The following is a description of a gene set: studied in species Homo sapiens CD25, the high affinity interleukin-2 (IL-2) receptor alpha-chain, is rapidly upregulated by antigen-specific CD8+ T cells after T cell receptor stimulation. We demonstrated that during an acute viral infection, CD25 expression was dynamic, and a subset of virus-specific CD8+ T cells sustained CD25 expression longer than the rest. Examination of the in vivo fate of effector CD8+ T cells exhibiting differential responsiveness to IL-2 revealed that CD25lo cells, which were relatively less sensitive to IL-2, preferentially upregulated CD127 and CD62L and gave rise to the functional long-lived memory pool. In contrast, CD25hi cells that accumulate enhanced IL-2 signals, proliferated more rapidly, were prone to apoptosis, exhibited a more pronounced effector phenotype, and appeared to be terminally differentiated. Sustained IL-2 receptor signaling resulted in increased CD8+ T cell proliferation, higher granzyme B expression and exaggerated contraction after antigen clearance. These data support the hypothesis that prolonged IL-2 signals during priming promote terminal effector differentiation of CD8+ T cells. Genes up-regulated in comparison of naive vs effector CD8 T cells (3.5 days postinfection). from publication Kalia V, Sarkar S, Subramaniam S, Haining WN, Smith KA, Ahmed R (PMID 20096608) Human Gene Set: GSE19825_NAIVE_VS_DAY3_EFF_CD8_TCELL_UP, and this is the list of marker genes: ATP1B1, SNED1, TTC3, CRISPLD1, APLP2, HHIP, LIX1, ZFX, SLC22A25, IGF2BP1, SV2A, CYP11A1, PTCH2, PARD3, IGFBP4, ASTL, EPDR1, SPARCL1, GPR182, SYN1, MOBP, DIO3OS, UROC1, KCNA2 (NCBI Gene Id 3737), ANO1, ADAMTS9, ART1, SPTBN2, PAPSS2 (3'-phosphoadenosine 5'-phosphosulfate synthase 2), TTLL10, ACVR1, STMN4, FUT9, ZNF420, NEUROG3, LEPR, GAS1, MYH6, ANGPT4, YIPF7, CORO2B, NREP, PAX3, SLC2A5, FOXA2, CRACD (capping protein inhibiting regulator of actin dynamics), IGSF21 (immunoglobin superfamily member 21), KCNK13, POMT2, CLRN3, PLCL1, HCN3, TUBB4A, ARHGEF40, C16orf86, PTGS2, PCLO (piccolo presynaptic cytomatrix protein), EPN2, NRIP2, BACE2, TNFRSF11A, FAM90A13 (NCBI Gene Id 619424), LCE2B, ST6GALNAC1, XPNPEP2, HSD3B1, CCDC22, GPR12, FAM227A, VGLL3, ADGRE1, REM2, CIMIP6, TFAP2A, ELAVL4, MTUS2, COL5A2, MACROH2A2, IGF1R, TMEM266, SLC12A8, TMEM86B, PIGP, PRR16 (NCBI Gene Id 51334, proline rich 16), ZFPM2, INTU, TFF3, DRP2, ZNF691, FCGR2B, LBP, DYDC2, CSF3, CFI, BPIFA2, ZNF536 (NCBI Gene Id 9745), COPZ2, WNT1, SH3GL3, TMEM8B, FRS3, SRPK3, ADARB1, TSPAN7, CRYL1, HDAC11, VSTM2L, TEX13A, KRT75, SLC35F1, GDF3, SPATA3, SEMA3F, CYFIP1, GOT1L1, LOXL2, FAM78B, ADD2, AIF1L, TRPA1, PCDHB12, PLA2G6, GPR26, PNMA3, COL8A1, CTSK, SLC29A4, KCND2, NXPH1, DNAH6, DACT3, HTRA3, BDKRB1, SCML2, RHBDL3, DPYSL4, EPCAM (epithelial cell adhesion molecule), FLT4, KIF1B, CSF1R, DLK1, C1QL1, SV2B (NCBI Gene Id 9899), TCEA2, AJM1, FMO2, NPY, C2orf81, GSTM1, MYBPH, PCDHB7, ELAVL2, TMEM151A, ACE, CCDC83, PTCHD1, SPATS1, HPCA, KCNH3, CEACAM20, MROH2B, NES, HOXB3, FMO4, COL1A2, ADGRG3, PDE10A, TPMT, CEACAM21 (CEA cell adhesion molecule 21), FSTL5, TMEM270 (NCBI Gene Id 135886), PTPRN, KBTBD13, SYPL2, NEUROD4, CXCL2, SLC8A1, RHO, DUOXA2, MYOZ1, GPR162, HOOK3, PRMT8, NBL1, RHBDD2, KDF1, CPNE6 (NCBI Gene Id 9362), DEPTOR, TET3, CCDC184, CBY3, IFT88, ADGRL2, FAM171A2, ADCY5, FAM43B, TMEM200C (NCBI Gene Id 645369), CSDC2, SYP, SLC22A7